Given this list of marker genes Ramac, Anxa1, Kdm1a, Nop10, Bcdin3d, Grsf1, Trim32, Mrps7, Rars1, Aqr, Mov10l1, Pym1, Tut1 (NCBI Gene Id 70044), Nova1, Rbm27, Tlr3, G3bp1, Sox9, Sf1, Rbm14, Lsm6, Alyreffm5, Cyfip1, Cpeb2, Tert, Wbp4, Ago2, Klf4, Sf3b3, Zc3h6, Pnldc1, Tra2a, Mrpl24, Eif3k, Mir21c (NCBI Gene Id 102465212), Oas1d, Tfb2m, Rps5, L1td1, Nip7, Pus7l, Rnps1, Tst, Mrm3, Ppan, Nsun2, Snu13, Hnrnpm, Bysl, Rpl22, Srsf8, Nelfe, Hnrnpul1, A1cf, Eif4a3l2, Celf6, Ikzf1, Wdr43, Rbm26, Slbp, Pop5, mt-Ti, Mir7116, Rsl1d1, Trp53, Dcp1a, Eif2c5l, Elavl1, Mrps27, Suz12, Mir484, Msi2 (musashi RNA-binding protein 2), Celf4, Dusp11, Wdr82, Helz2, Larp6, Mir23a, Rps16, Ddx3y, Tent5c, Rbm48 (NCBI Gene Id 269623), Dazl, Mtrfr, Dkc1, Mvk, Syncrip, Rps10, Drosha, Crnkl1, Rbpms, Paip1, Fubp3, Sf3a3, Rbmxl2, Hnrnpab, Ddx20, Pa2g4, Rbmyf1, Tnrc6c, Mrps18c, Exosc5, Scaf1, Elp5, Dhx37, Prpf40a, Hexim1, Lsm10, Eif3i, Trub1, Vim, Nxf7, Larp4b, Srp19, Snrpa1, Ppargc1b, Zranb2, Piwil1, Pkm, Adar, Srrm2, Lipe, mt-Tc, mt-Tv, Mex3b, Zc3h12c, Rbmyf6, Ago3, Snrpa, Nsrp1, Mrps17, Dhx8, Sugp1, Safb, Rpl7, Igf2bp3, Eif4a3l1, Scaf8, Auh, Stau1, Mir24-1, Rbms2, Gemin7, Rbfox1, Dlx2, Prpf39, Thoc2l, Dus2 (dihydrouridine synthase 2), Adarb1, Prkra, Ppp1r10, Habp4, Hspa8, Nemf (nuclear export mediator factor), Rcc1l, Slc3a2, Ifit1bl1, Ddx50, Tra2b, Dhx58, Arb2a, Srp54a, Cdk9, Srp14, Khdc3, Rpl3l, Dazap1, Zc3h12d, Fars2, Mex3d, mt-Tl2, Hnrnph1 (NCBI Gene Id 59013), Thoc6 (NCBI Gene Id 386612), Utp23, Elavl4, Tnrc6b, Lsm11, Isg20, Rpp25, Snrpb2, Khnyn, Zfp36l1, Dxo, Wrap53, Rps2, Rnasel, Utp25, Rbm8a2, Rps3a1, Rbm42, Arc, Aco1, Sars2, Rbm46, Ddx10, Mir409, Dhx57, Hnrnph2, Ybx1, Larp1, Raver1, Cpeb1, mt-Ty, Trap1, Jmjd6 (NCBI Gene Id 70547), Adad1 (adenosine deaminase domain containing 1), Hmga1, Rpl10a, Apobec2, U2af1, Eif4e3, Rbm4, Rida, mt-Tp, N4bp1, Ddx55, Usp17lc, Lin28a (NCBI Gene Id 83557), Rbm12b1, Fbl, Trmt10a, Mbnl3, Lsm14a, Poldip3, Rps13, BC005624, Ddx51, Rps3, mt-Tl1, Pcid2, Zc3h12b, Zfp346, Rpusd1, Mir21b, Piwil4, Rps26, Papolg, Pabpn1l, Rbmx2, Nudt4, Fastkd1, Ptrh1, Tlr13, Dgcr8, Tut7, Mir124-2hg, Prkdc, Hbp1, Nat10, Puf60, Tfrc, Rbm12, Ddx28, Endou, Rbm22, Nsun3, Cct5, Prpf6, Rara, Mrpl11, Pcbp4, Ctu1, Xrcc5, Sart3, Heatr1, Pcp4, Cwc22rt7, Rpl4, Dicer1, Rps19, Dnmt3a, Piwil2, Rbm20, Ooep, Dtd1, Ccnt2, Angel2, Caprin1, Raver2, Tlr9, Gpbp1l1 (NCBI Gene Id 80277), Wdr6, Srek1, Zc3h4, mt-Ts1, Alyref, Atxn1l, Grb7, Srsf10, Wdhd1, U2af1l4, Sfpq, Hdlbp, Gpbp1, Fastkd5, Nol8, U2af2, Khdrbs1, Carhsp1, Tlr8, Hnrnpf, Dhx29, Fyttd1, Rps7, Dhx34, Xrn2, Zc3h7b, Nono, Calr, Nudt7, Prpf4, Dis3l2, Cwc22rt3, Exosc4, Eif5a, Khdc1c, Upf3b, Alyreffm10, Ifit1 (NCBI Gene Id 15957), Snupn, Sfswap, Lrpprc, Eif4e1b, Rbm19, Alkbh1, Rpl13a, Nudt1, Pabpn1, Fech, Znfx1, Elavl3, Snrpf, Ddx31, Mtdh, Snrpd3, Rpl14, Rbbp7, Sde2, Slfn9, Xrn1, Nop56, Aars2, Wt1, Ddx41, Thumpd2, Eif1b, Trmt10c, Tbl3, Ddx47, mt-Td, Sidt1, Slc4a1ap, Fam120a, Ddx59, Sepsecs, Rftn1, Ahcyl1, Srsf9, Thumpd1, Rpl22l1, Toe1, Nol6, Brca1, Igf2bp2, Rbm34, Zc3h12a, Rpl7l1, Per2, Csde1, Rnaseh2a, Nelfb, Zar1, Srp72, Cwc22rt4, Exosc6, Pno1, mt-Tq, Hnrnpul2, Ireb2, Psma6, Thoc3, Pdia3, Ddx24, mt-Tm, Dcps, Sf3b5 (splicing factor 3b, subunit 5), Imp3, Spi1, Fastkd2, Hsp90ab1, Eif4g1, Sf3b4, Rps18, Nanos2 (nanos C2HC-type zinc finger 2), Dnd1, Gnl3, Mdm2, Pcbp3, Magohb, Iars1, Papola, Cpsf4, Trmt9b, Rc3h1, Cwc22rt1, Nom1 (nucleolar protein with MIF4G domain 1), Mrpl18, Rplp0, Zfp385a, Usp17ld, mt-Ts2 (mitochondrially encoded tRNA serine 2), Edc3, Cdc5l, Xpo1, Dimt1, Ezh2, Trmt1l, Nanos3, Tfb1m, Rps20, Lsm8, Ddx5, Pabpc4, Pop7, Usp17le, Rpl30, Oas2, Rad21, Rbpms2, Pkp1, Tial1, Aars1, Xpo5, Slpi, Trim71, Dhx32, Rbm15b, Ddx18, Cpsf3, Ythdf3, Tdrd7, Dhx30, Nop9, Arhgef28, Srbd1, Uhmk1, Rps15, Skic2, Elp1, Brd3, Rpf1, Fmr1, Secisbp2, Son, Phf5a, Tbrg4, Matr3, Pstk, Sbds, Mir124a-2, Mrps18a, Rrp12, Cars1, Hsp90b1 (NCBI Gene Id 22027), Mirlet7g, Atp2a2, Rpusd4, Usp17lb, Nlrp6 (NCBI Gene Id 101613), Ankrd17, Trub2, Oas1c, Cstf2, Rbm10, Hnrnpdl, Cdc40, Pprc1, Cpsf7, Shmt1, Cbx4, Khdc1b, Map3k20, Eif1ad, Hspd1, Aptx, Pes1, Parn, Snrpb, Kin, Samd4, Yy1, Esf1, Ddx1, Zc3hav1, Kcnq1ot1, Dzip3, Pabpc2, Snd1, Hnrnpa3, Rbm28, Brix1, Gpatch8, Tyw5, Casp7, Larp7, Cbx7, Rrs1, Rbm33, Rbmxl1, Hnrnpu, Rpl7a, Hars1, Ddx19a, Pus1, Snrnp70, Pinx1, Ddx3x (NCBI Gene Id 236681), Patl1, Dalrd3, Kars1, Lsm2, Trim21, Ptbp3, Eif3g, Snip1, Copa, Trmu, G3bp2, mt-Ta, Rtraf, Nufip1, Mrpl16, Srsf7, Ddx19b, Nifk, Eif2d, Lsm3, Cpsf1, Ddx46, Srsf4, Rnaset2a, Zrsr2, Spout1, Mrpl21, Sirt6, Trmo, mt-Th, Ccnt1, Mrm1, Nxf3, Pum2, Ncl, Mrps5, Prdm14 (PR domain containing 14), Mrpl13, Utp6, Mir135a-1, Srsf6, Rbm38, Adat1, Lsm14b, Nudt21, Jakmip1, Zc3h7a, Cnot7, Snrnp35, Cstf2t, Rbm31y, Mecp2, Endov, Zfp638, Oas1a, Luc7l, 2810429I04Rik, Farsa, Ro60, Zc3h10, Apobec3, Sugp2, Mex3c, Ctif, Zfp36l2, Cltc, Bicc1, Cwc22rt6, Fam76b, Lrrc47, Tex13a, Mrps9, Srp54c, Eif4g2, Rpp25l, Prpf8, Stat3 (NCBI Gene Id 68733), Gtpbp4, Ddx43, Sin3a, Paip2, Rbm6, Gemin6, Tdrkh, Cbx6, Dppa5b, Rpusd2, Rpusd3, Esrp1, Serbp1, Gm15290, Ager, Cnot4, Mir124a-3, Celf5, Ncbp3, Lactb2, Impdh2, Nsun7, Rnf40, Alyreffm4, Dtd2, Eif2a, Eif3c, Slfn2, Rpl13, Hnrnpk, Tex19.2, Spen, Frg1, Nsun4, mt-Tt, Rbm17, Xpot, Cwc22, Dppa5a, Adad2, Setx, Sf3b1, Ythdf1, Cherp, Rnaset2b, Qki, Zcchc8, Purb, Trmt11, Dhx35, Pan3, Zfr2, Pcbp2, Coil, Hnrnpc, Boll, Alyreffm2, Baz2a, Dis3, Polr2g, Zc3h8, Rbm45, Chtop, Mcts1, Mcrip2 (MAPK regulated corepressor interacting protein 2), Rae1, Srf, Pdcd11, Mir124a-1, Dhx9, Mettl14, Oas1g, Mbnl1, Sarnp, Jrk (jerky), Esrp2, Alyreffm3, Khsrp, Mov10, Srsf11, Ilf2, Tent4b, Hnrnpll, Dcp1b, Trmt10b, Fxr2, Nudt16l2, Cpeb4, Exosc7, Eno1, Mir361, Ang, Gtsf1, Exd1, Ddx52, Fastk, Hnrnpa2b1, Csdc2, Nlrp1b, Ilf3, Tsn, Rpl6, Ifih1 (NCBI Gene Id 71586), Rpl23a, Dnmt3b, Mir874, Oas1h, Samhd1, Pkp3, Ddx4, Usp17la, Sra1, Hsd17b10, Hnrnpd, Mir505, Helz, Rpl37, Ascc1, Wdr75, Rps27l, Hadhb, U2surp, Adarb2, Smg7, Fubp1, Yrdc, Srp9, Ewsr1, Rpp40, Strap, Rbm11, Thra, Smg5, Dqx1, Marf1, Rbms1, Elp3, Rpf2, Exosc8, Zc3h14, Sox2, Eif1ax, Surf6 (surfeit gene 6), Rps27, Rrp9, Unc50, Mtpap, Shfl, Celf3, Eif4e, Prpf40b, Tardbp, Rbms3, Iars2, Ppme1, Rps14, Larp4, Gar1, Rbmyf9, Eif5a2, Ppie, Lsm4, Ccdc9, Eprs1, Khdrbs2, Alyreffm6 (Aly/REF export factor family member 6), Eif2ak4, Pspc1, Rpl19, Rbmx, Aicda, Raly, Arglu1, Srsf2, Nkap, Atxn1, Eef2, Fgfr3, Mrpl12, Taf15, Hnrnpa1 (heterogeneous nuclear ribonucleoprotein A1), Slu7, Zcrb1, Mepce, Sugt1, Nsun5, Zmat3, Zcchc3, Celf1, Trnau1ap, Thoc7, Gpatch1, Rbmyf3, Ybx2, Cnot8, Zfp36l3, Rbm18, Mir539, Tpr, Eif3d, Rad51ap1, Oasl2, Scaf4, Dars1 (NCBI Gene Id 319692), Akap17b, Hnrnph3, Dnmt1, Eif4enif1, Cstf3, Mettl1, Magoh, Rpp30, Eefsec, Ppp1r8, Eral1, Cryz, Ppargc1a, Ncbp2, Gm7324, Supv3l1, Pabpc6, Taco1, Cpsf6, Rpl26, Nxf1, Mir466l, Ddx60, Nlrp1a, Rbm4b, Nynrin, Rnmt, Rigi, Snrpe, Rbm39, Pabpc1, Farsb, Etf1, Rpl8, Eif1, Tubb4b, Zbed4, Mettl3, Rpl9 (NCBI Gene Id 20005), Ep300, Eif2ak2, Eif4h, Rpp14, Bard1, Mir21a, Rpl3, Pabpc4l, Ears2, Pus10, Msn, Apex1, Nop53, Patl2, Mir9-1, Ptbp1, Hnrnpr, Cwc15 (CWC15 spliceosome-associated protein), Mrpl20, mt-Tk, mt-Tg, Alyreffm14, Tsr1, Sidt2, Nelfcd, Srsf3, Ptcd1, Mir24-2, Supt5, Snord87, Eif4e2, Snrpd1, Pdcd4, Rnf20, Ssb (NCBI Gene Id 228007), Ptbp2, Smndc1, Zar1l, Lsm7, Nol9, Thoc5, Casc3, Rpl12, Mphosph6, Rbm8a, Cirbp, Eif2s3y, Hmgb3, Nup98, Mir294, Mbnl2, Upf3a, Prkcsh, Setd1b, Eya1, Mif4gd, Rbm12b2, Nudt16l1, Phax, Lsm5, Henmt1, Thoc2, Pum3, Tia1, Rps11, Snrpd2, Hars2, Lsm12, Dhfr, Mrpl1, Tuba1b, Mki67, Ythdf2, Ddx25, Gtpbp1, Mrps6, Prpf31, Pabpc1l, Npm2, ENSMUSG00000126352, Fus, Pum1, Rpl35, Trdmt1, Rbm44, Noct, Mael, Ago1, Hexim2, mt-Tr, Rbm15, Larp7-ps, Eif3b, Ptcd3, Pou1f1, Ralyl (RALY RNA binding protein-like), Alkbh8, Smn1, Ddx39b, Tyms, Cwc22rt2, Gtf3a, Ddx54, Luc7l2 (NCBI Gene Id 75005), mt-Te, Setd1a, Nhp2, Khdc1a, Exosc10, Srrm4, Arid5a (NCBI Gene Id 214855), Yars2, Synj1, Gtpbp2, Actn1, Oasl1, Nanos1, Fbll1, Rpp38, Ramacl, Rdm1, Rbm5, mt-Tw, Nolc1, Eif2s2, Nudt16, Cpsf2, Gpkow, Eif1a, Rnpc3, Smad1, Aff2, Mrpl44, Cluh, Myh4, Myef2, Ddx6, Eif2s1, Sf3b6, Nr0b1, Rbm43, Trnt1, Rpl17, Mbd2, Rps6, Rpl24, Rbmy, Upf2, Alyreffm1, Emg1, Drg2, Smarca4, Nol12, Dnajc17, Zcchc7, Ppil4, Park7, Eef1a1, Ubr5, Nop2, Srp68, Khdc4, Exosc3, Ppp5c, Rrp7a, Ifit2, Eif4b, Sltm, Nudt5, Pus7, Tex13c1, Tnrc6a, Fxr1, mt-Tf, Ythdc1, Pou5f1, Khdrbs3, Usp36, Mrpl2, Exosc2, Hspa1a, Ncbp1, Paip2b, Akap1, Sf3a1, Trmt2a, Rpl18, Ngrn, Dna2, Snrpc, Dhx40, Tep1 (NCBI Gene Id 546226), Yars1, Nufip2, Oas1f, Ybx3, Lonp1, Ddx56, Alyref2, Rps4x, Angel1, Dhx36, Rpl15, Zfp106, Zcchc17, Celf2, Mcts2, Tut4, Ppp1r21, Rbm24, Zfp36, Pax6, Cdkn2aip, Ighmbp2, Mettl16, Pcf11, Rbm7, Eri1, Fastkd3, Ifit1bl2, Cpeb3, Bms1, Cyfip2, Tarbp2, Wdr3, Hmgb1, Sox4, Sars1, Smg6, Rbfox2, Secisbp2l, Cnot6, Mir27b, Papolb, Pabpc5, C1d, Imp4, Mir186, Nsun6 (NOL1/NOP2/Sun domain family member 6), Redic1, Dhx16, Zcchc13, Pop4, Hsp90aa1, Krr1, Mir701, Tex19.1, Rbm25, Elavl2, Ythdc2, Abt1, Lin28b, Fip1l1, Tex13c3, Apobec1, Mtrex (NCBI Gene Id 72198), Oas1b, Eif2s3x, Naa38, Pcbp1, Mtres1, Rpl11, Snrpg, Rpl23, Zgrf1, Pop1, Riox1, Nop14 (NOP14 nucleolar protein), C1qbp, mt-Tn, Myh10, Eif4g3, Cnbp, Thoc1, Mex3a, Rbm41, Samd4b, Cbx8, Pus3, Oas1e, Npm3, Gemin5, Ctbp1, Nova2, Igf2bp1, Rangap1, Msi1, Rbfox3, D1Pas1, Ddx11, Slfn8, Trmt1, Srsf1, Enox2, Rbm47, Rpp21, Luc7l3, Eif4a2, Rps6-ps4, Dhx15, Rps9, Ddx39a, Srrm1, Carlr, Prkrip1, Zbp1, Ran, Htatsf1, Socs3, Dhx38, Exosc9, Pnpt1, Myhas, Exosc1, Synj2, Eftud2, Stau2, Ddx49, Tsnax, Mir125b-1, Unk, Tex13d, Npm1, Ddx42, Btg4, Upf1, Rpl5, Cavin1, Lsm1, Nabp1, Mir1896, Ago4, Ranbp2, Dcp2, Qtrt2 (queuine tRNA-ribosyltransferase accessory subunit 2), Srsf5, Mcrs1 (NCBI Gene Id 97957), Nxf2, Atxn2l, Morc3, Eif3a, Api5, Mterf4, Kdm2b, Eif5b, Dhx33, Eif4a1, Snrpn, Trir, Cwc22rt5, Tlr7, Peg10, Cnp, Rc3h2, Cdh2, Srp54b (signal recognition particle 54B, NCBI Gene Id 665155), Nop58, Ddx23, Eif4a3, Pusl1 (NCBI Gene Id 76548), Mars1, Ctu2, Nicol1, Zfr, Hmga1b, Safb2, Smarce1, Oas3, Hnrnpl, Naf1, Rbm3 (RNA binding motif (RNP1, RRM) protein 3), Mir125b-2, Dis3l, Qars1, Atxn2, Thumpd3, Ddx17, Srrm3, Tex16, Strbp, Tdrd9, Enox1, Mthfsd, Hnrnpa0, Aimp1, Slirp, Ddx21, Caprin2, here is a description of the gene set: Mouse Gene Set: GOMF_RNA_BINDING Binding to an RNA molecule or a portion thereof. species: Mus musculus